The following is a description of a gene set: Mouse Gene Set: SOX13_TARGET_GENES species: Mus musculus from publication Yevshin I, Sharipov R, Kolmykov S, Kondrakhin Y, Kolpakov F (PMID 30445619) Genes containing one or more binding sites for (Sox13) in their promoter regions (TSS -1000,+100 bp) as identified by GTRD version 20.06 ChIP-seq harmonization., and this is the list of marker genes: Tafa5, Ezr, Rnf44, Gm2061, Ldlrad1, Atrn, Rasgef1c, Dph2, Setd2, Smpd2, Rad52, A130014A01Rik, Ss18, Wnt7b, Adamtsl3, Slc11a1, Zdhhc7, Pag1, Tomm20l, Csnk1d, A930032L01Rik, Urgcp, Zap70, Upk1b, A730017L22Rik, Cfap20dc, Bag6, Lats2, Aknaos, Rnf114, Apbb1ip, 1700025A08Rik, Otx2, Arl8a, Stat5b, Sez6, Ulk2 (NCBI Gene Id 320511), Palb2, Ttc16, Larp1b, Cops7a, Pnkd, Lrrc56, Slc25a41, Dctn5, Scube2, Tmem123, Gm22267, Hras, 3110053B16Rik, Pidd1, Abcd3, Igfbp2, 3110056K07Rik, Ttc39d, Fdx1, Ppil6, Gm336, Hk1, Cdc73, Chst2 (NCBI Gene Id 54371), Arid4a, Pex5, Sema4f, Gm5298 (NCBI Gene Id 384308), Ech1, 4930540M05Rik, Gm3235, Dnaaf9, Zbtb18, 4930455B14Rik